Given this list of marker genes Adamts6, Notch3, Nfatc3, Ngfr, Ndst1 (NCBI Gene Id 74141), Bmpr1a, Dctn5, Prickle1 (prickle planar cell polarity protein 1, NCBI Gene Id 68784), Lep, Notch4, Cntrl, Gla, Hoxa13, Nprl3, Edn1, Ap2b1, Ddit3, Hey2, Rtn4, Hey1, Apoe, Foxc1, Fkbp10, Gaa, Pdgfrb, Apob, Chrd, Gli3, Scn11a (sodium channel, voltage-gated, type XI, alpha), Nrp1, Lrp1, Sec24b, Cxcr4, Tab1, Fgf8, Naglu, Wnt11, Acvrl1, Hes1, Nkx3-1, Efnb2, Adgrf4, Adamts9, Arid2, Lox, Ptger4, Snx17, Nog, Enpp1, Six1, Foxc2, Robo2, Mir145a, Kif7 (kinesin family member 7), Mylk, Sufu, Zmiz1, Nf1, Ldlr, Stra6, Ednra, Comp, Eya1, Robo1, Kat6a, Notch1, Ephb4, Tfap2b, Vegfa, Shh, Hhipl1, Sox4, Pde2a, Hoxa1, Mdk (NCBI Gene Id 17242), Cited2, Rbpj, Chd7, Prrx1, Tbx2, Srf, Fam3d, Lrp2, Efemp2, Bmp4, Pkd2, Akt3, Fuz, Ltbp1, Gja5, Hectd1, Comt, Mexis, Tgfb2, Smad7, Tgfbr2 (NCBI Gene Id 76304), Mir143, Adgrf5, Tgfbr1, Prrx2, Hand2, Bmpr2, Plxnd1, Col3a1, Foxh1, Prdm1, Smarca4, Slc2a10, Foxf1, Myh10, Egr2, Acvr2b, Myocd, Eng, Hpgd, Dnm2, Megf8, Jag1, Folr1, Aplnr, Luzp1, Angptl3, Tbx1, Prox1, Ctnnb1, Pcdha9, Smad6, Dll4, here is a description of the gene set: Mouse Gene Set: GOBP_ARTERY_DEVELOPMENT studied in species Mus musculus The progression of the artery over time, from its initial formation to the mature structure. An artery is a blood vessel that carries blood away from the heart to a capillary bed.